The following is a description of a gene set: Propensity for subsequent distant metastasis in head and neck squamous-cell carcinoma (HNSCC) was analysed using 186 primary tumours from patients initially treated by surgery that developed (M) or did not develop (NM) metastases as the first recurrent event. Transcriptome (Affymetrix HGU133_Plus2, QRT-PCR) and array-comparative genomic hybridization data were collected. Non-supervised hierarchical clustering based on Affymetrix data distinguished tumours differing in pathological differentiation, and identified associated functional changes. Propensity for metastasis was not associated with these subgroups. Using QRT-PCR data we identified a four-gene model (PSMD10, HSD17B12, FLOT2 and KRT17) that predicts M/NM status with 77% success in a separate 79-sample validation group of HNSCC samples. This prediction is independent of clinical criteria (age, lymph node status, stage, differentiation and localization). The most significantly altered transcripts in M versus NM were significantly associated to metastasis-related functions, including adhesion, mobility and cell survival. Several genomic modifications were significantly associated with M/NM status (most notably gains at 4q11-22 and Xq12-28; losses at 11q14-24 and 17q11 losses) and partly linked to transcription modifications. This work yields a basis for the development of prognostic molecular signatures, markers and therapeutic targets for HNSCC metastasis. Up-regulated genes that vary between HNSCC (head and neck squamous cell carcinoma) groups formed on the basis of their level of pathological differentiation: well vs moderately differentiated tumors. Human Gene Set: RICKMAN_TUMOR_DIFFERENTIATED_WELL_VS_MODERATELY_UP species: Homo sapiens from publication Rickman DS, Millon R, De Reynies A, Thomas E, Wasylyk C, Muller D, Abecassis J, Wasylyk B (PMID 18679425), and this is the list of marker genes: ZNF207, COMMD7, UBL3, MYB, LEF1, MSI2, MECOM, EML4, CNPY3, SP4, ACSS1 (acyl-CoA synthetase short chain family member 1), MRPL33, GLCCI1, AHSA2P, ME2, P4HTM, WBP1, ZNF747, EZH1, ZNF550, DNAJC4, C2CD5, SSBP2, TRIM2, PASK, LPIN1, JTB, PHF8, ATRAID, ATAD2B, PRKAR2B, ASXL2, CYP4X1, ARHGEF26, LMO4, CLCA4, SFT2D3, ETNK2, HEATR5B, SOS1, TARBP1, MAP2K6, IQCB1, NCOA1, EYA2, LBH, DIPK2A, TMTC2, NPRL2, ZNF704, SYNPO2, PDCD4, BCL11A, IGFBP5, FAM171A1, HEY1, CHPT1, ZDHHC2, IFT172, TSPAN6, DZIP3, EEIG2, MAP7D2, THAP9-AS1, CLN3, GSTM4, ALDH5A1, KRT13, GGT7, SRSF7, PBX1, ENPP4, CCT6P3, CAPS, GPD1L, KAT6B, TMEM150C (transmembrane protein 150C), ASB3 (NCBI Gene Id 51130), FAM118A, E2F5, SMDT1, SCPEP1, USP21, ABHD12, TRAF5, ZNF513, SERTAD4, PLCB1, ZBTB18, SLC27A1, RARB, MYLIP, PIK3R3 (phosphoinositide-3-kinase regulatory subunit 3), ANKH, ABCC5, KRT4, PLCB4, GGA2, GATM, SUOX, TMX4, FAM117A, TMT1A, TIFA, SUSD4, KAT7, EDEM2